Given this list of marker genes LIPA, SH2B3, TLR8, CTLA4, ITK, TCF4, APOE, PRF1, GPR35, CYBA, DNASE2, ZNFX1, HAVCR2, LYST, SMPD1, MST1, SLC7A7, NEU1, JAK2, XIAP, STXBP2, SLC29A3, NPC2, ASAH1, NCF2, CYBB, HLA-DPA1, IFNGR1, SEMA4D, CBLB, IFNG, NCF1, CALR, PRTN3, SGCG, CD27, NPC1, HLA-DPB1, PIK3CG, STX11, RAB27A, GLB1, MPL, PTPN22 (protein tyrosine phosphatase non-receptor type 22), SH2D1A, UNC13D, SAMD9L, here is a description of the gene set: An abnormality of macrophages. Human Gene Set: HP_ABNORMAL_MACROPHAGE_MORPHOLOGY Abnormal macrophage morphology species: Homo sapiens